Given this list of marker genes KDM4B (lysine demethylase 4B), HTT (NCBI Gene Id 3064), IFNA4, TRANK1, CHD8, WNT7A, IRF1, CRABP2 (cellular retinoic acid binding protein 2), KIF3B, RAB5C, SCN3B, PPP1R11, MAP4K4, N4BP2L2, MAP3K11, AP1S1, STXBP2, TNNI1, OCEL1, ZNF91, ORAI2, PPP4C, CACNA1A, CAPG, PDPK1, DEPDC5, LTB, CSNK1G2, RAMP2, CD99, WIPF2, UBA1, ELL2, CEP350, HOXC5, KLF12, INSL3, USP4, KIFC1 (NCBI Gene Id 95229), MAPT, BCL2, IGHA1, NHERF1, MXD4, RHOG, PTPN1, KCNB1, ZFY, PDE4C, GNAT2, NME3, FGFR1, SELENOW, SPTAN1, JUND, TNRC6B, GRAMD1B (NCBI Gene Id 57476), GPSM3, CDK10, RELA, PLEKHM2, YJU2 (YJU2 splicing factor homolog), ZBTB7A, NKX2-5, CCNI, ATP6V0D1, IL2RG, ADA, RALY, PCYT1A, ARHGAP35, L3MBTL1, CNOT3, CBFA2T3, STAT6, ACTN4, NR2F6, SIPA1 (signal-induced proliferation-associated 1), BTF3, S1PR4, PITPNM1, KMT2B, PTK2B, GNB2, CSK, MYO9B, ALDH3B2, GUSBP14, BRCA2, ARPC4, UPK1A, POU2F2, ACAP1, PI4KB, SNX1, PTPRS, SMAD9, PIGQ, DCAF7, BRD2, TYK2, RPRD2 (NCBI Gene Id 23248), ERCC2, ITGAD, EGR1, STAT3 (signal transducer and activator of transcription 3), IFNA16, UGT1A10, ZSCAN9, CDKL1, CYBA, SCAP, TAPBP, MAP3K7, ST3GAL1, STX16, ARHGAP25, S100A11, CRHR2 (NCBI Gene Id 1395), HLA-DRB6, REEP1, SFTPC, PCOLCE, RAD51D, FLNA, GAB1, ICAM3, here is a description of the gene set: Proliferation of higher eukaryotic cells is triggered by the proto-oncogene c-myc (myc), which is induced downstream of a large number of growth factor receptors. Myc, a basic helix-loop-helix leucine zipper transcription factor, transmits growth signals by up- and downregulation of target genes. The importance of Myc in growth control is well established. However, the number of growth control genes requiring Myc as an essential factor for regulation after mitogenic stimulation of cells is not yet clear. Here, we have studied the transcriptional programme of a human B-cell line, P493-6, in response to Myc and serum. P493-6 cells do not express the endogenous myc, nor is it induced by serum stimulation. Proliferation of the cells is dependent upon both the expression of a tetracycline-regulated myc gene and serum stimulation. Using DNA microarrays, expression profiling was performed following stimulation of cells with serum, with Myc, or with both. We observed serum regulation of >genes. A number of these genes were synergistically or antagonistically regulated by Myc. Moreover, we identified >300 Myc-regulated genes that were almost unresponsive to serum. Gene ontology analysis revealed that a high proportion of Myc target genes are involved in ribosome biogenesis and tRNA metabolism. The data support our current notion that Myc is essential for the regulation of a large number of growth-related genes in B cells, and cannot be replaced by other serum-induced factors. Human Gene Set: SCHLOSSER_SERUM_RESPONSE_UP from publication Schlosser I, Hölzel M, Hoffmann R, Burtscher H, Kohlhuber F, Schuhmacher M, Chapman R, Weidle UH, Eick D (PMID 15516975) Cluster 1: genes up-regulated in B493-6 cells (B lymphocytes) upon serum stimulation but not by affected by MYC. studied in species Homo sapiens